Given this list of marker genes MYH2, TSPAN8, PTGR3, KLHL41, OTOP3, OTX1, TGFB3, CLDN18, SYT10, IGF1, PHEX, GABRR1, TMOD3, ZBTB37, LINC01101, SH3RF1, MCC, NTN5, PDCD1LG2, CTCF, ID2, NAALADL2, FOXB1, SEMA5B, IBSP, PITX2, ADAMTS13, ALDH1A2, BTBD3, PLS3, NDP (NCBI Gene Id 4693), ATXN7L2, KLF12, NEDD4, TBX4, TRPS1, RIPOR1, SHOX2 (NCBI Gene Id 6474), PURA, SLC34A3, FBXL22, TMCC1, TAF5L, EVX1, PER2, HS3ST4, PNRC1, MYL6B, MSC, IER5, PUM2, CALD1, TNMD, CDKN1A, SLC24A2, FOXD3, UTP25, FRY (NCBI Gene Id 404759), HOXC6, CAMK1D, PDZRN4, ULK1, DGKI (diacylglycerol kinase iota), SNX13, BRAF, TCEANC2, PTH1R, TCF7L2, PHTF2, BCLAF3, LMO3 (NCBI Gene Id 55885), OSR2, EYA1, KCNQ5, USP34, PTAFR, DUSP1, TLE3, NNAT, VASN, TLX1, HNF1A, FERD3L, VIT, KCNJ13, GOLPH3L, ZC3H6, FGF9, BTBD8, ABI3BP, ERG, INHBA (NCBI Gene Id 3624), LOX, C7orf33, PDE7A, CADM1, TMEM59, FOXP2, FAM53B, SCML1, PRPS1L1, CRCT1, HMCN1, HOXD9, SLC31A1, TET2, UBE2H, HR, SIN3A, ZFX, BPIFA1, LEF1, CITED2, HOXC4, LMO4 (NCBI Gene Id 8543), ETHE1, ZNF385B, ADRB1, KBTBD2, PHLPP1, CD109, PTCHD1, PPP2R3A, CLIP2, MBNL2, AP1G2, PELI2, TAFA1, POU3F3, TECTA, EMP1, RBM39, HEPH, NUDT18, AMER1, HSPG2, TENM1, UBXN10, RARG (NCBI Gene Id 5916), PRDM1, TMEM147, COLEC12, IKZF2, CALHM5, NR4A1 (nuclear receptor subfamily 4 group A member 1), ROR1, RUNX1T1, MAST4, HOXA11, GFRA1, SKIDA1, NCDN, SPRY4, here is a description of the gene set: Human Gene Set: FREAC4_01 species: Homo sapiens Genes having at least one occurrence of the motif CTWAWGTAAACANWGN in the regions spanning 4 kb centered on their transcription starting sites. This matches the FOXD1 transcription factor binding site V$FREAC4_01 (v7.4 TRANSFAC).